Given this list of marker genes PYGM, AGL, GAA, ENO3, PHKG1, AMPD1, PHKA1, PFKM, NADK2, here is a description of the gene set: studied in species Homo sapiens Human Gene Set: HP_ABNORMAL_ENZYME_ACTIVITY_IN_MUSCLE_TISSUE Abnormal enzyme activity in muscle tissue Deviation from the normal activity of an enzyme in muscle tissue.